The following is a description of a gene set: Human Gene Set: GOBP_REGULATION_OF_RELEASE_OF_SEQUESTERED_CALCIUM_ION_INTO_CYTOSOL species: Homo sapiens Any process that modulates the frequency, rate or extent of the release into the cytosolic compartment of calcium ions sequestered in the endoplasmic reticulum or mitochondria., and this is the list of marker genes: ANK2, IL13, LYN (LYN proto-oncogene, Src family tyrosine kinase), TMEM38B, HTT, MIR133A1, FKBP1B, PLN, CORO1A, DMD, PTK2B, BDKRB1, LACRT, NTSR1, F2, THY1, ABL1, F2R, CXCL10, DHRS7C, CASQ1, ATP1A2 (NCBI Gene Id 93186), UBASH3B, JPH4, NGF, CASQ2, APLNR, HAP1 (NCBI Gene Id 9001), HRC, BAX, CX3CL1, SNCA, LIME1, GPER1 (G protein-coupled estrogen receptor 1), PRKACA, ATG5, F2RL3, KCNK16, TRPC1, METTL21C, GSTM2, PRKCE, SRI, CAPN3, CEMIP, TGFB1, PDPK1, CALM2, JPH2, PTPN6, FKBP1A, CXCL9, PDE4D, GSTO1, MIR93, CACNA1C, XCL1, ASPH, TMEM38A, DRD1, ITGB3, PRKD1, NPSR1, SLC8A1, JPH1, AKAP6, CXCR3, CXCL11 (NCBI Gene Id 6373), DIAPH1, TRDN, CALM1, CYBA, P2RY6 (NCBI Gene Id 5031), JPH3, CAMK2D, MIR1-1, CLIC2, CD19, RYR2, PLCG1, CHD7, CALM3, SELENON